The following is a description of a gene set: From late mitosis through G1 phase APC/C:Cdh1 insures the continued degradation of the mitotic proteins and during mitotic exit and G1 its substrates include Cdc20, Plk1, Aurora A, Cdc6 and Geminin (see Castro et al., 2005). Rape et al. have recently demonstrated that the order in which APC/C targeted proteins are degraded is determined by the processivity of multiubiquitination of these substrates. Processive substrates acquire a polyubiquitin chain upon binding to the APC/C once and are degraded. Distributive substrates bind, dissociate and reassociate with the APC/C multiple times before acquiring an ubiquitin chain of sufficient length to insure degradation. In addition, distributive substrates that dissociate from the APC/C with short ubiquitin chains are targeted for deubiquitination. part of: APC/C-mediated degradation of cell cycle proteins Reactome Pathway: APC/C:Cdh1 mediated degradation of Cdc20 and other APC/C:Cdh1 targeted proteins in late mitosis/early G1 species: Homo sapiens, and this is the list of marker genes: PSMC6, ANAPC2, UBE2E1, PSMD14, ANAPC7, PSMD13, PSMD11, PSMA4, ADRM1, AURKB, PSMD6, PSMD3, UBE2S, PSMB3, UBE2D1, PSMD8, PSMA1, RPS27A, PSMC3, RB1, ANAPC11, PSMD12, ANAPC10, CDC16, PSMC5, ANAPC1, PSMA7, ANAPC16, PLK1, PSMD2, CDC20, PSMC1, AURKA, PSMD1, PSMC4, PSMA3, SEM1, CDC26, PSMB4, ANAPC4, CDC27, PSMB2, CDC23, PSMA5, UBE2C, PSMA6, ANAPC15, PSMD7 (NCBI Gene Id 5713), SKP2, PSMA2, PSMB7, UBA52, PSMC2, ANAPC5, PSMB1, PSMB6, UBC, PSMB5, UBB, FZR1, PTTG1